Given this list of marker genes Vamp2 (NCBI Gene Id 22318), Slc6a1, Slc6a13, Cplx1, Syt1, Stx1a, Rab3a, here is a description of the gene set: electronically inferred by orthology from the curated human pathway This event has been computationally inferred from an event that has been demonstrated in another species.<p>The inference is based on the homology mapping from PANTHER. Briefly, reactions for which all involved PhysicalEntities (in input, output and catalyst) have a mapped orthologue/paralogue (for complexes at least 75% of components must have a mapping) are inferred to the other species. species: Mus musculus part of: Neurotransmitter release cycle Reactome Pathway: GABA synthesis, release, reuptake and degradation